Given this list of marker genes Pirt, Htt, Actn2, Nipsnap2, Stimate, Calm1, Lrrc55, Akap7, Nedd4l, Fgf14, Lrrc52, Akap6, Stac2, Asph, Lrrc26, Scn1b, Cacnb3, Stim2, Stim1, Lrrc38, Ehd3, Cracr2a, Atpsckmt, Jph2, Ank3, Stac, Cacnb2, Calm2, Rnf207, Calm3, Ank2, Ctss, Pkd2, Gsto1, Gal, Plcg2, Edn1, Galr2, Ikbkb, Stac3, Casq1, Nppa, Fgf13, Hap1, Gstm7, Ednra, here is a description of the gene set: studied in species Mus musculus Mouse Gene Set: GOBP_POSITIVE_REGULATION_OF_CATION_CHANNEL_ACTIVITY Any process that activates or increases the frequency, rate or extent of cation channel activity.